Given this list of marker genes COL1A2, MYH3, LMX1B, RBBP8 (RB binding protein 8, endonuclease), HOXD13, TLK2, MET, ATR, GDF5, MASP1, WNT7A, CHST11, ADAMTS15, NOG, TNNI2, IHH, ROR2, PIEZO2, TPM2, TBX15, here is a description of the gene set: species: Homo sapiens Abnormal finger flexion crease Human Gene Set: HP_ABNORMAL_FINGER_FLEXION_CREASE Anomalous flexion crease (i.e., a transverse line that crosses the skin of a finger).